The following is a description of a gene set: Any process that results in a change in state or activity of a cell or an organism (in terms of movement, secretion, enzyme production, gene expression, etc.) as a result of a bleomycin stimulus. Human Gene Set: GOBP_RESPONSE_TO_BLEOMYCIN studied in species Homo sapiens, and this is the list of marker genes: TIMELESS, DDX11 (NCBI Gene Id 93260), FOSL2, C6orf89, COL6A1 (NCBI Gene Id 1291)